The following is a description of a gene set: Neuroinflammation Activation of the brain's innate immune system in response to an inflammatory challenge and is characterized by a host of cellular and molecular changes within the brain. Human Gene Set: HP_NEUROINFLAMMATION species: Homo sapiens, and this is the list of marker genes: IL6, CCR1, HLA-B (major histocompatibility complex, class I, B), POLG, NLRP3, KLRC4, IFNGR1, PRORP, HLA-DRB1, IL12A-AS1, MIF, MEFV, C4A, TLR7, IKBKG, IL10, TLR4, CTLA4, ERAP1, STAT4, LACC1, NOD2, IL23R, IL12A, FAS, TK2, UBAC2